Given this list of marker genes NDC1 (NDC1 transmembrane nucleoporin), NUP93, NUP153, RTN4, AHCTF1, FXR1, TMEM170A, TPR, NUP205, NUP98, NUP107, here is a description of the gene set: Human Gene Set: GOBP_NUCLEAR_PORE_COMPLEX_ASSEMBLY studied in species Homo sapiens The aggregation, arrangement and bonding together of a set of components to form a nuclear pore complex.